Given this list of marker genes EGFR, TGFA, EPGN, BTC, AREG, HBEGF, PLCG1, EREG, EGF, here is a description of the gene set: studied in species Homo sapiens part of: Signaling by EGFR Reactome Pathway: EGFR interacts with phospholipase C-gamma Activated epidermal growth factor receptors (EGFR) can stimulate phosphatidylinositol (PI) turnover. Activated EGFR can activate phospholipase C-gamma1 (PLC-gamma1, i.e. PLCG1) which hydrolyses phosphatidylinositol 4,5-bisphosphate (PIP2) to inositol 1,4,5-triphosphate (IP3) and diacylglycerol (DAG). IP3 is instrumental in the release of calcium from intracellular stores and DAG is involved in protein kinase C activation.